The following is a description of a gene set: Mouse Gene Set: GOBP_SPERMINE_METABOLIC_PROCESS The chemical reactions and pathways involving spermine, a polybasic amine found in human sperm, in ribosomes and in some viruses, which is involved in nucleic acid packaging. Synthesis is regulated by ornithine decarboxylase which plays a key role in control of DNA replication. studied in species Mus musculus, and this is the list of marker genes: Paox, Sms (spermine synthase), Amd1, Sat1, Sat2, Smox, Amd2